Given this list of marker genes CTSC, ELANE, ALMS1, GFI1, NCF2, IRF9, SLC6A19, CD40LG, ITGB2, GJB2, PLEKHM1, B4GALT7, STAT3, PLG, CYBA, ELOVL4, TCIRG1, GJB6, SRP19, CLPB, SAMD9, CYBC1, SEC61A1, OCRL, SLC37A4, CLTRN, NCF4, KRT6A (NCBI Gene Id 93086), NCF1, LYST, CYBB, COL3A1, FERMT1, CAT, here is a description of the gene set: Inflammation of the gingiva. Human Gene Set: HP_GINGIVITIS species: Homo sapiens Gingivitis